Given this list of marker genes GPR107, C5orf15, POLR3F, UTS2, RGCC, TAF9, MTMR8, EXO1, SLC35F6, GADD45G, WWC1, BICD1 (NCBI Gene Id 636), DLX6 (NCBI Gene Id 1750), FEN1, GFAP, PAPOLA, LGALS3BP, RIN3, HNF1B, KRIT1, MKLN1, UMPS, CHRNA1, THTPA, ABTB2, UBQLN3, GSK3A, CHST5, DNAJC6, RORA (NCBI Gene Id 6095), C3, F11R, CEACAM7, VPS13B, APOC1, MAN1B1, SCNN1D, FCRL2, ZNF337, UBE2D4 (NCBI Gene Id 82030), LIG3, BORCS6, JPH3, FAP, MARS1, ZNF3, SCRN3, MTRR, STX1A, PPP1R14B, TIPIN, APOD, INTS7 (integrator complex subunit 7), PPIA, SKA1, OPA1, UGT2A3, CCZ1B, DCLK1, VHL, SHH, GALNT2, GPR4 (G protein-coupled receptor 4), KCNMB1, MOG, ZCCHC14, PGF, RGS12, ENSG00000274253, LTK, ARFIP1, NPTXR, THUMPD2, RHD, GNG12, GDF2 (growth differentiation factor 2), PSMB6, SIPA1L1, ELK4, PHTF2, CKAP2, LASP1, OVGP1, EXPH5, SLC22A18AS, LINC01711, CTSK, FOCAD, B2M, ACSF2, MIPEP (NCBI Gene Id 4285), RAD54L2 (NCBI Gene Id 23132), RAB3D, ANGPT2, PTPRD (NCBI Gene Id 5789), OGFOD2, STMN2, CTNNAL1, CDH2, FBXW11, DNAH3, NCAM2, IFT57, CHMP1A, SLC12A9, ARF6, GATD3, IKZF3, GREB1L, ADPGK, IL1R2, NPVF, HCG9, YES1, LSS, ZNF154 (NCBI Gene Id 7710), CFTR, ACADSB, RANBP17, MCM6, PLLP, RSAD1, S100A6, SSBP1, ATP2A2, SBNO1, CRKL, ADGRB2, FAM50A, COX4I1, NFIB, SCEL, SFTPB, BCL2L1, INO80B, ASCL3, UBE3B, GPR171, SOX11, LARGE1, CHST3, MRPL34, EXOSC2, EVC, CRNN, RRAS2, ZFC3H1, IRS1, REPS1 (RALBP1 associated Eps domain containing 1), H2AC17, SLC35D2, ARHGEF15, TMEM9B, SRPX2, INA, SEPTIN4, GPRC5B, ALG5, FSCN3, CMAHP, FSTL1, TCP10L, SLC2A6, PTK2B, THSD7A, TGFBR3 (NCBI Gene Id 7049), RASL11B, INTS15, FHL5, EMC8, PRDM10, KLRC3 (killer cell lectin like receptor C3), ELF3, HOXD1, AURKAIP1, CYB5R3, NPY6R, FEZ1, YTHDC1, RAB11FIP3, SDC2, SAV1, ZNF146, MATCAP2, IRS4, POGLUT1, RPS6KA1, SLC17A4, NLRP2, INAVA, TPM3, KIF2C, ZBTB44, NME5, MC2R, MTMR11, here is a description of the gene set: Genes up-regulated in HEK293 cells over-expressing wildtype NOD2: untreated versus muramyl dipeptide for 6h. Human Gene Set: GSE22611_UNSTIM_VS_6H_MDP_STIM_NOD2_TRANSDUCED_HEK293T_CELL_UP NOD2 is an intracellular receptor for the bacterial cell wall component muramyl dipeptide (MDP) and variants of NOD2 are associated with chronic inflammatory diseases of barrier organs e.g. Crohn disease, asthma and atopic eczema. It is known that activation of NOD2 induces a variety of inflammatory and antibacterial factors. The exact transcriptomal signatures that define the cellular programs downstream of NOD2 activation and the influence of the Crohn-associated variant L1007fsinsC are yet to be defined. To describe the MDP-induced activation program, we analyzed the transcriptomal reactions of isogenic HEK293 cells expressing NOD2wt or NOD2L1007fsinsC to stimulation with MDP. Importantly, a clear loss-of-function could be observed in the cells carrying the Crohn-associated variant L1007fsinsC, while the NOD2wt cells showed differential regulation of growth factors, chemokines and several antagonists of NF-κB, e.g. TNFAIP3 (A20) and IER3. studied in species Homo sapiens from publication Billmann-Born S, Till A, Arlt A, Lipinski S, Sina C, Latiano A, Annese V, Häsler R, Kerick M, Manke T, Seegert D, Hanidu A, Schäfer H, van Heel D, Li J, Schreiber S, Rosenstiel P (PMID 21335489)